Given this list of marker genes PLXND1, PLXNA4, TYROBP, CD72, PLXNB3, SEMA7A, SEMA3E, SEMA4D, ITGA1, PLXNA2, PLXNA1, ITGB1, PTPRC, SEMA6D (NCBI Gene Id 80031), SEMA6A, SEMA4A, PLXNC1, TREM2, SEMA5A, here is a description of the gene set: There are eight classes of semaphorins and four types of plexins. Semaphorin (SEMA) classes 1 and 2 are found in invertebrates and classes 3-7 are vertebrate sempahorines. Sempahorin class 3 is secreted, whereas the other classes are synthesised as transmembrane proteins. Vertebrate plexins (PLXNs) are classified into four subfamilies plexin-A to -D. There are four A-type plexins, three B-type, one C-type and D-type. Interactions between different subfamilies of plexins and semaphorins show differential specificity, which trigger different sets of biological functions. Another level of functional specificity specificity is attained by plexins by coupling with various coreceptors expressed in a cell- or tissue-specific manner, such as neuropilins (NRP), L1CAM, c-MET proto-oncogene, ERB2, CD72 and CD45. part of: Semaphorin interactions studied in species Homo sapiens Reactome Pathway: Other semaphorin interactions